The following is a description of a gene set: species: Homo sapiens Human Gene Set: MODULE_318 Genes in the cancer module 318., and this is the list of marker genes: CHD3, ZNF254, RAD51C, RAD51, FOS, DDX5, DHX9, CHD4, XRCC6, ELOA, GTF2F2, RAD51D, RECQL4, BLM, STAT2, XRCC3, HELZ, ERCC3, WRN, RAD51B, CITED2, MCM3 (NCBI Gene Id 4172), MCM6, XRCC5, MYCN, DDX10, DDX11 (NCBI Gene Id 93260), JUNB